Given this list of marker genes Col1a2, Tgfbr3, Cd109, Kmt2a, Pbld2, Nrros, Sox6, Zbtb7a, Npnt, Smad1, Sox11, Ryr1, Dcp1a, Zyx, Sirt1, Chst11, Pdgfd, Fam89b, Arap1, Stat3, Map3k7, Gipc1, Star, Rbbp7, Nkx2-1, Dnmt1, Pak2, Scx, Cdh3, Sin3a, Sox9, Spry2, Cldn1, Hdac1, Mef2c, Itgb1, Ltbp1, Lats1, Rock2, Cd2ap, Snw1, Ptk2, Snx1, Spred2, Mir145b, Dusp22, Pml, Stk16, Xbp1, Mir155, Ankrd1, Gdf15, Postn, Pdpk1, Ptprk, Zfyve9, Arrb2, Smad6, Adam17, Rbbp4, Zmiz1, Lrg1 (NCBI Gene Id 76905, leucine-rich alpha-2-glycoprotein 1), Smurf2, Zfp36l1, Pmepa1, Itgb8, Prdm16, Rock1, Bmpr1a, Parp1, Twsg1, Nfkbiz, Dnm2, Zfp451, Ndp, Nr3c1, Hipk2, Usp9x, Cflar (NCBI Gene Id 98571), Pin1rt1 (NCBI Gene Id 241593), Rasl11b, Pdcd5, Trim33, Spred1, Fbn2 (fibrillin 2), Il4, Mir145a, Onecut1, Cited2 (NCBI Gene Id 17684), Col4a2, Nepn, Onecut2, Eid2, Wnt5a, Tgfbr3l, Pin1, Acvr1c, Cilp, Mir192, Gcnt2, Map3k1, Suds3, Usp15, Gdf10, Skil, Ppm1a, Pals1, Rnf111, Ing1, Fkbp1a, Il17rd, Ctsk, Tgfbr2, Dbn1, Eng, Wnt1, Zfp703, Ltbp3, Sox5, Aspn, Smad4, Fndc4, Lrrc25, Mir143, Smad9, Amhr2, Tgfb3, Wnt2, Ppargc1a, Ccl2, Htra3, Zfp36l2, Fbn1, Nlk, Pparg, Cav2, Cx3cr1, Bambi, Itga8, Hdac2, Crk, Myocd, Axin1, Wnt10a, Smurf1, Penk, Furin, Actr3, Ski, Igf1r, Cidea, Hsp90ab1, Il17f, Smad7, Nos3, Col3a1, Sap30, Cdkn1c, Fyn, Tgfb1, Cdh5, Ints9, Tnrc6c, Zfhx3, Adam9, Slc2a10, Sdcbp, Lemd3, Pxn, Veph1, Fshb, Ogt, Crebbp, Lrp1, Src, Fermt2, Itga3, Wwox, Kdm6a, Mir21a, Dab2, Bmp2, Ddr2, Ltbp4, Wfikkn2, Htra1, Nrep, Wnt4 (NCBI Gene Id 22417), Ppara, Hspa5, Bcl9l, Smad2, Yes1, Acvrl1, Edn1, Dcstamp, Wnt7a, Apaf1, Adissp, Lgals9, Sfrp1, Stub1, Wfikkn1, Pdcd5-ps, Tab1, Brms1, Thbs1, Cav3, Pde3a, Cdkn2b, Got1, Epb41l5, Hyal2, Ep300, Hpgd (NCBI Gene Id 234274), Cripto, Strap, Crkl, Ldlrad4, Abl1, Lrrc32, Smad3, Mapk7, Vasn, Flcn, Tgfb1i1, Zeb2, Lpxn (NCBI Gene Id 319643), Peg10, Fut8, Fermt1, Ero1a, Dand5, Brms1l, Men1, Tgfbr1, Ovol2, Glg1, Fos, Smad5 (NCBI Gene Id 76327), Spry1, Gdf2, Cav1 (NCBI Gene Id 12389), Serpine1, Lats2, Acta2, Xcl1, Sap130, Snx6, Spred3, Appl2, Bmp8a, Bmp8b, Tsc22d1, Selenon, Lox, Folr1, Skor2, Arid4b, Cited1, Tgfb2, Sap30l (NCBI Gene Id 50724), Gdnf, Runx3, Nodal, Emilin1, Cldn5, Stk11, Col1a1, Akr1c18, Itgb5, Runx1, Snx25 (NCBI Gene Id 382008), Bmpr1b, Ing2, Foxh1, Adamtsl2, Dlx1, Sinhcaf, Mstn, Tet1, Spi1, Arid4a, Itgb6, Appl1, Creb1, Zeb1, Acvr1, Jun, Trp53, Pbld1, here is a description of the gene set: species: Mus musculus Any process that results in a change in state or activity of a cell or an organism (in terms of movement, secretion, enzyme production, gene expression, etc.) as a result of a transforming growth factor beta stimulus. Mouse Gene Set: GOBP_RESPONSE_TO_TRANSFORMING_GROWTH_FACTOR_BETA